Given this list of marker genes MAPK8 (NCBI Gene Id 5599), DAXX, PARK7, MAPK10, MAPK9, MAP3K5, here is a description of the gene set: Pathway Definition from KEGG: DJ1* // (DAXX+ASK1) -> JNK studied in species Homo sapiens Human Gene Set: KEGG_MEDICUS_VARIANT_MUTATION_INACTIVATED_DJ1_TO_FAS_JNK_SIGNALING_PATWHAY Mutation-inactivated DJ1 to FAS-JNK signaling patwhay. Pathway ID: N01057. Pathway type: Variant. Pathway class: nt06463 Parkinson disease.